The following is a description of a gene set: from publication Chen Y, Wang X (PMID 31504780) studied in species Homo sapiens Human Gene Set: MIR652_5P Genes predicted to be targets of miRBase v22 microRNA hsa-miR-652-5p in miRDB v6.0 with MirTarget v4 prediction scores > 80 (high confidence targets)., and this is the list of marker genes: MAPK8, SLC25A24, CPEB2, TOP1, PRKCA, MACF1, TSPAN9, UNC79 (NCBI Gene Id 57578), PLD6, CDC25B, GABPB2, ZBTB44, ATF7IP, PARP8, NEMP1, RAB14 (NCBI Gene Id 51730), NDUFAF4, PPP4R2, NRBF2, PATZ1, DSG1, SPAG9, EGLN1, GPM6B, TRIM2, SEC14L1, SETD5, MAP1B, TMTC2, SIM1, C15orf48, RBPJ, MRS2, C2CD4A, FBXO3, CFTR